The following is a description of a gene set: Catalysis of the hydrolysis of peptide bonds between an alpha-carboxyl group and an alpha-amino group within a small protein such as ubiquitin or a ubiquitin-like protein (e.g. APG8, ISG15, NEDD8, SUMO). Human Gene Set: GOMF_UBIQUITIN_LIKE_PROTEIN_SPECIFIC_ENDOPEPTIDASE_ACTIVITY species: Homo sapiens, and this is the list of marker genes: SENP5, SENP2, SENP1, SENP6, SENP7